The following is a description of a gene set: from publication Tabula Muris Consortium (PMID 32669714) Mouse Gene Set: TABULA_MURIS_SENIS_KIDNEY_KIDNEY_PROXIMAL_CONVOLUTED_TUBULE_EPITHELIAL_CELL_AGEING species: Mus musculus, and this is the list of marker genes: Sgk1, Ddt, Rps23, Rps7, Rpl13, Ftl1, Nenf, Lgmn, Oaz1, Rpl18a, Gsta4, Gabarapl1, Ass1, Gas5, Selenop, Clec2h, Bex4, Rps3a1, Slc7a7, Gpx1, Snhg11, Rps24, Malat1, H2bc4, Lyplal1, Rpl6, Actg1, Cxxc5, Rps13, Pdp2, Ndrg1, Hint1, H2-D1, Tmem254, Rps29, Rplp2, Fbp2, Atxn1, Rps12, Tmem37, Rps6, Tmem106a, Jun, Slc43a2, Rps2 (NCBI Gene Id 16898), Epb41l3, Rps15a, Sectm1b (secreted and transmembrane 1B), Rpl41, Nabp1, Spsb4, H1f2, Mgst1, Rpl5, Ldhd, Gabarap, Dnajb4, Akr1a1, H2-Aa, Trf, Pnrc1, Apoe (apolipoprotein E), Sirpa, Hdc, Kap, Fis1, Rhob (ras homolog family member B), Sptssa, Irf2bp2, Gc, Npm1, Apob, B2m, Gsta3, Cnn3, Ybx1, Rps19, Map1lc3b, Rplp0, Camk2n1, Defb29, Degs1, Rps28, Rhobtb1, Rps10, Ddc, Ethe1, Gatm, Comt, Ddx5, Ipmk, Gstt1, Rps9, Gdf15, Tomm6, Cyp2c23, Tmsb4x, Sephs2, H2-Ab1, Zfp36l1, Ypel2, Rbm3, Eef1b2, Rpl10, Creg1, Gas6, Cd74, Tstd1, Mrfap1, Clta, Rtn4, Neat1, Chka (NCBI Gene Id 12660), Mafg, Rpl4, Gnpda1, Ube2b, Rcan1, Cyp24a1, Arvcf, Rps27, Cyp2d12, H2-K1, Cela1, Rpl37a, Rpl21, Slc16a1, Acss1 (NCBI Gene Id 99069), Acsl1, Slc3a2, Rps15a-ps4, Cox7a2l, Tpt1 (tumor protein, translationally-controlled 1), Eif1, Nuak2 (NCBI Gene Id 74137), Klf6, Pakap, Slc13a1 (NCBI Gene Id 55961), Ascc1, G6pc1, Slc5a12, Rps26, Jund, Rps4x, Ccnd1, Rpl36al, Rps20, Srsf5, Rpl3, Sult1c2 (sulfotransferase family, cytosolic, 1C, member 2), H2-Eb1, Ost4 (NCBI Gene Id 67695), Mocs2, Rps27a, Npl, Maf (NCBI Gene Id 78336), Bax, Rps5, Tceal8, Rsrp1, H3f3b, Rpl9, Vkorc1, Dusp1, Mdk, Isoc2a, Psap, Rpl7, Dhrs3, Rps16, Ccn1, Smim22, Rps21, Slc25a3, Ifi27, Id2, Rps14, Sec61g, Rnf186, Spns3, Fos, Slco1a6